The following is a description of a gene set: Human Gene Set: HP_CHEST_PAIN An unpleasant sensation characterized by physical discomfort (such as pricking, throbbing, or aching) localized to the chest. studied in species Homo sapiens Chest pain, and this is the list of marker genes: DLST, DBH, TGFBR1, KIF1B, PNPLA2, PRTN3, MYL2, HLA-B, TGFBR2, SCNN1A, SDHB, MAX, FH, NOS1, ABCC9, FOXE3, NOD2, SCN3B (sodium voltage-gated channel beta subunit 3), CAV3, DNMT3A, THPO, SMAD4, TNNC1, HLA-DPB1, PIGA, SCN2B, MT-TK, PRKG1, GJA5, STAT3, SCN4A, CFTR, SDHA, SDHD, IRAK1, GATA5, PPOX, PTPN22, MEFV, SDHC, GNAS, APC, SLC34A2, SCNN1G, STX16, VHL, KCNE2 (NCBI Gene Id 9992), TMEM127, HLA-DRB1, DLEC1, NF1, COL4A5, MYL4, HLA-DQB1, HBB, SMAD3, TSC1, GATA6, CTNNB1, MAT2A, TET2, MEF2A, NPPA, PRKAR1A, RNF6, HLA-DQA1, RASA1, CALR, DPM3, KCNJ3, HLA-DPA1 (NCBI Gene Id 7935), SCN1B, ACTC1, WWOX, IL12B, TP53, ELN, MYBPC3, SCN4B, MYLK, SCN5A, PPA2, ENG, ACTA2, TNFRSF1A, KCNE1, TMEM43, NUP155, FBN1, EPAS1, TTN, KCNA5, WAS, EXT2, THSD4, PITX2, CTLA4, SH2B3, ADAMTS19, RET, SLC25A11, NKX2-5 (NCBI Gene Id 1482), STAT4, BAP1, CDH2, COL3A1, TGFB2, WIPF1, SAT1, COL4A6, LOX, SPP1, JAK2, KCNJ5, DSG2, BTNL2, MDH2, CRLF1, NKX2-6, KCNJ2, EXT1, SMAD2 (NCBI Gene Id 654050), PLN, MYH11, TGFB3, GATA4, MYH7, HEY2, PRKAG2, MPL, TSC2, MFAP5, MLX, SCNN1B, SDHAF2, KCNQ1, IRF4